Given this list of marker genes Myo7a, Clrn2, Clic5 (chloride intracellular channel 5), Gsdme, Alg10b, Ankrd24, Mir96, Esrp1, Cux1, Mycl, Scrib, Sec24b, Pdzd7, Ercc3 (NCBI Gene Id 13872), Gfi1, Elmod3, Dll1, Ush1c (NCBI Gene Id 72088), Ush2a, Ripor2, Dlx3, Myo6, Pls1, Hes1, Fgf20, Lamc1, Clrn1, Pou4f3, Fgfr1, Slc4a7, Whrn, Grxcr2, Hey1, Slc44a4, Fgfr3, Hes5, Ptprq, Triobp, Minar2, Jag1 (NCBI Gene Id 170642), Sod1, Pafah1b1, Nherf1, Rac1, Myo3b, Tmc1, Kcnq1, Atp2b2, Atoh1, Tmem132e, Pcdh15, Bmp4, Hey2, Mcoln3, Myo3a, Rbpj, Jag2, Grxcr1, Tprn, Rest, Fgf2, Mycn, Kcnma1, Cdh23, Tecta, Slitrk6, Lhfpl5 (lipoma HMGIC fusion partner-like 5), Ercc2, Wdpcp, Strc, Tomt, Notch1, Tgm3, here is a description of the gene set: species: Mus musculus The process in which a relatively unspecialized cell acquires specialized features of a hair cell. Mouse Gene Set: GOBP_HAIR_CELL_DIFFERENTIATION